Given this list of marker genes MYF6, IL18, N4BP2L2 (NCBI Gene Id 88523), EPB41L4A, ATG2A (NCBI Gene Id 23130), DNAJB12, ZNF132, PER2, SPP1, MARCHF1, CDKN3, SH3BP4, PDK3, AGO2, TRIP6, PRR16, SYNJ2, TEX41, SERPINB4, SORBS2, PLAUR (plasminogen activator, urokinase receptor), SPRY1, MYLK3, MINAR1, POLM, E2F8, MANEA, VAPA (NCBI Gene Id 9218), GPR37, UQCRQ, KIF3B, NDUFA4, SDC4, TSPOAP1, TIMM9, ERVMER34-1, SEC24D, P2RY1, OR1G1, PRSS21, FDFT1 (NCBI Gene Id 2222), GINS2, ACSL3, NDUFAF4, SLC66A1, CENPU, RLIG1, MMP10, CNGB3, COPG2IT1, TXN, ACTR3B, IRS1, SULT1B1, SPTSSA, ERAP2, TNFRSF1A, ARPC3, OLFML1, KLHL29, PRAMEF11, RPL7, SNORA21, COX7C, AZI2, DLG5, JAM3, TIMM8B, CYP2E1, NAIP, PPP1R3D, CATSPERB, RPS7, ARMCX1, UAP1, HS3ST3A1, DSTYK, LEPROTL1, PBX3-DT, RPL21, MRC1, HPGD, CDK2AP1, C11orf71, WWOX, ELOVL6, AFF4, SPICE1, TACSTD2, IFI44L, EPHA4, PLK2, RPS23, ID2B, TYROBP, PI4KA, CHD5, VLDLR, CHAF1A, RBM8A (NCBI Gene Id 9939), TRAM1, FOSL1, ZNF415, PBK, UBE2A, WT1-AS, NOX4, SPC25, GABPB1-IT1, SYNPO2L, PCLAF, SNAPC1, KLF3-AS1, TTC28, MNT, FZD9, UBFD1, XYLT1, TMED9, CSNK2A1, SPATA2, NSMF (NCBI Gene Id 349336), ZFY, VEZF1, EPHX1, SNX24, HEXIM1, GNGT1, TMCO3, KLHL11, LMF1, NT5DC2, LINC00216, TIMM8A, SLC22A5, ELK4, CCL20, COL16A1, ENSG00000274253, NEDD4, CEBPD, SLC18A1, EEF1E1, ZSCAN12, ENTPD7, PMM2, FBXL4, MRPL33, C21orf91, HBE1, ZNF639, MED14, MAGED1, HSPB7, GID4, TOP2A, SLC22A11, PIEZO2, ADAM17, TMEM185B, AUTS2, TAX1BP3, NR2C2, SEPHS2, BCL7B, DIP2A, PLOD2, KANSL2, LRRC20, LTK, CAPNS1, ZDHHC4, AKR1C2, MAGEH1, PFDN4, CCDC59, POU2AF1, RPA3, KIF18B, GSPT1, MAP3K20, RIPK4, DPYS, RABL3, SHCBP1, CEP162, MNS1, ANK1, ZC2HC1A, MC4R, SLC19A3, CR2 (complement C3d receptor 2), PTPRE, ITIH2, OR7C1, here is a description of the gene set: species: Homo sapiens Human Gene Set: GSE36476_YOUNG_VS_OLD_DONOR_MEMORY_CD4_TCELL_UP from publication Yu M, Li G, Lee WW, Yuan M, Cui D, Weyand CM, Goronzy JJ (PMID 22434910) With increasing age, the ability of the immune system to protect against recurring infections or to control chronic infections erodes. The objective of the current study was to identify gene expression signatures in elderly CD4 T cell responses Genes up-regulated in comparison of untreated memory CD4 T cells from young donors versus those from old donors.